Given this list of marker genes IGSF3, TP63, HLA-DRB1, FGFR2, BTNL2, PRMT7 (NCBI Gene Id 54496), LEMD3, SATB2, here is a description of the gene set: Dacryocystitis Human Gene Set: HP_DACRYOCYSTITIS studied in species Homo sapiens Inflammation of the nasolacrimal sac.